Given this list of marker genes CLCNKA, CLCN4, SLC17A3, TMC4, GPR89A, CLCN2 (NCBI Gene Id 79179), ANO1, CLCN6, VDAC3, VDAC2, GPR89B (NCBI Gene Id 728932), CLCNKB, ANO6, CLCN1, CLCN3, VDAC1, CLCN5, here is a description of the gene set: Human Gene Set: GOMF_VOLTAGE_GATED_MONOATOMIC_ANION_CHANNEL_ACTIVITY Enables the transmembrane transfer of an anion by a voltage-gated channel. An anion is a negatively charged ion. A voltage-gated channel is a channel whose open state is dependent on the voltage across the membrane in which it is embedded. studied in species Homo sapiens